Given this list of marker genes COQ4, DHFR, HSP90AA1, COQ2, NOS3, COQ6, STARD7, PTS, SPR, COQ3, GCH1 (GTP cyclohydrolase 1), AKT1, PDSS1, ACO1, PRKG2, COQ7, PDSS2, HPDL, COQ5, IDH1, COQ8A, CALM1, COQ8B, GCHFR, COQ9, here is a description of the gene set: Human Gene Set: REACTOME_METABOLISM_OF_COFACTORS Metabolism of cofactors studied in species Homo sapiens